The following is a description of a gene set: species: Mus musculus Signal attenuation Mouse Gene Set: REACTOME_SIGNAL_ATTENUATION, and this is the list of marker genes: Sos1, Irs2, Ins1, Grb2 (growth factor receptor bound protein 2), Insr, Mapk1 (mitogen-activated protein kinase 1), Mapk3, Grb10, Shc1